Given this list of marker genes Shld1, Ino80, Ruvbl1, Nbn, Rtel1, Ino80b, Acd, Terf2, Actl6a, Dclre1b, Xrcc1, Ruvbl2, Apex1, Ercc4, Tfpt, Yy1 (NCBI Gene Id 22632), Ino80c, Ercc1, Actr5, Shld2, Terf2ip, Actr8, Mcrs1, Cdk2, Shld3, Uchl5, Ino80d, Pot1b, Mad2l2, Ppp1ca, Xrcc4, Rif1, Nfrkb, here is a description of the gene set: Any process that occur in response to the presence of critically short or damaged telomeres. Mouse Gene Set: GOBP_TELOMERE_MAINTENANCE_IN_RESPONSE_TO_DNA_DAMAGE studied in species Mus musculus